Given this list of marker genes RAE1, NUP205, RANBP2, CPSF3 (cleavage and polyadenylation specific factor 3), CPSF4, NUP93, SYMPK, SEC13, WDR33, NUP107, NDC1, NUP210, ALYREF, NUP35, NUP133, SLBP, AAAS, NUP54, NUP153, NUP85, NUP42, FIP1L1, NUP160, NUP62, NCBP2, EIF4E, CPSF1, NUP50, NUP214, SEH1L, NUP43, NUP88, NUP155, NUP98, TPR (NCBI Gene Id 7175), NUP37, NXF1, POM121, NCBP1, POM121C, NUP58, NUP188, CPSF2, here is a description of the gene set: Human Gene Set: REACTOME_TRANSPORT_OF_MATURE_MRNAS_DERIVED_FROM_INTRONLESS_TRANSCRIPTS Transport of Mature mRNAs Derived from Intronless Transcripts species: Homo sapiens